The following is a description of a gene set: species: Homo sapiens Genes up-regulated during primary acute viral infection: NK cells versus CD8A dendritic cells. Human Gene Set: GSE45365_NK_CELL_VS_CD8A_DC_MCMV_INFECTION_UP Murine Cytomegalovirus (MCMV) infection leads to early activation of various immune cells, including B and T lymphocytes, before the actual initiation of antigen-specific adaptive immunity. This activation is partly driven by innate cytokines, including type I interferon (IFN), which are induced early after infection. The objective of this study was to address the role of type I IFN in shaping early/innate B and T cell responses to a primary acute viral infection. In order to decipher the specific impact of IFN-I on cell subsets, we performed a genome-wide expression analysis on WT splenic B and CD8 T lymphocytes isolated from C57BL/6 mixed bone marrow chimera mice. This study complements series GSE39555, which focused on early responses of NK cells and of the two subsets of conventional dendritic cells., and this is the list of marker genes: MARVELD3, CNKSR1, CRIP1, WFDC9, WHRN, GPR157, TMEM45A, CCDC198 (coiled-coil domain containing 198), CLEC4G, ISG20, SH2D4B, SVIL, ABRA, HPRT1, LINC02946, OR2A4, TNFAIP3, ZNF365, SLC22A5, DPPA5, ZBTB46, ZNF107, EGF, PRAM1 (NCBI Gene Id 84106), XIRP1, OR11A1, CXCL8, PIGL, ZNF488, CNN3-DT (NCBI Gene Id 730758), SCCPDH, LAG3, LRRC3, SLC38A9, LPP, BIK, ATP6V0A2, NFE2L3, LONRF1, AGER, GFRA3, MFNG, TOR4A, EXOSC9, SPAST, CALN1, EDN1, ENKD1, PRKCZ-AS1, GGH, PLPP2, SMIM32, DCP1A (decapping mRNA 1A), KMT2E-AS1, POTEM, NFE2, KLK10, FLJ16779, ANO7, FBXL9P, SLC25A18, SDC2, KDSR, CD38, CLXN, GPN1, GPR62, SLC24A4, TBX6, VNN2, ANKUB1, ROR1, AKAP4, GNB5, PRDM11, LSM11 (LSM11, U7 small nuclear RNA associated), NDN, CHIC2, TEPSIN, DIO1, CCL20, GATA2-AS1, CH25H, SETD1B, CENPM, TTLL11, MANF, NIM1K, LGI1, NANOS3, PCDHA10, CALCB, DSCR9 (Down syndrome critical region 9), EVPL, SLC16A9, MRAP2, TXNDC15, TGDS, INSL3, KCNF1, SLC35A3, RSPO1, GCH1, TMEM30A, HCG22, NUP210L, CD69, DNAJA2, PHKG1, PAX8-AS1, CIMAP2, SGK1, LINC01304, SLC16A6, ATF6, MAGEB1 (NCBI Gene Id 8236), FAM133A, TAGLN, PROK2, PPP1R16B, OBP2A, SUMO2, NHEG1, YTHDF2, ZNF705G, LRRIQ3, RNF145, C3orf52, GJB6, ADAMTSL4, EGR3, EFNB1, DDAH1, IFNGR1, B4GALNT2, MYH13, SMIM6, CENPE, CXCL6, NCF1C, POGLUT1, FGG, HORMAD2, MARCO, MAP1LC3B, CARMIL2, SGCE, LGALS13, WBP2NL, PIGP, ABCC12, RAB17, SPMIP2, CYP4F2, GOLGB1, PAK1 (p21 (RAC1) activated kinase 1), CHADL, CD44, SLC35D2, ZRSR2P1, TMEM64, C6orf52, ENSG00000237870, H2AC8, FAM107A, TP53I11, CRAT, DNAJC7, SHC4, IL6ST, TNNC1, DIMT1, MT1M, SCGB1D1, CFAP184, TCP11L2, ARL6IP5, ATP6V1B1, FAM9A, CHDH, LST1, HGFAC, TNFRSF9, HMBOX1 (homeobox containing 1), RNF157-AS1, DELE1, DCUN1D2, INKA2-AS1, ZCCHC18, CALCA, IKBIP, GALNT7, OR10A5, B3GALT6, TLR9